Given this list of marker genes RIPK3, IL27RA, MED23, CD99L2, CCR2, FADD, here is a description of the gene set: Human Gene Set: GOBP_REGULATION_OF_T_CELL_EXTRAVASATION Any process that modulates the frequency, rate or extent of T cell extravasation. studied in species Homo sapiens